Given this list of marker genes TMEM199, ATP6V1B1, VMA21, ALDOB, CCDC115, TM9SF4, here is a description of the gene set: The aggregation, arrangement and bonding together of a vacuolar proton-transporting V-type ATPase complex, proton-transporting two-sector ATPase complex that couples ATP hydrolysis to the transport of protons across the vacuolar membrane. Human Gene Set: GOBP_VACUOLAR_PROTON_TRANSPORTING_V_TYPE_ATPASE_COMPLEX_ASSEMBLY studied in species Homo sapiens